Given this list of marker genes espC, HBB, hbp, tonB, dppA, dppD, mppA, dppC, exbB, exbD, dppB, chuA, HBA1, dppF, here is a description of the gene set: The ability to use iron derived from heme compounds represents an alternative iron uptake mechanism for enterobacteria growing in an iron-limited environment. Extracellular serine proteases of SPATE type (EspC, Hbp) cleave host hemoglobin, releasing free heme, which is imported by TonB-dependent receptors; binding of heme to a binding protein in the periplasm then enables cytosolic import by the ABC transporter DppBCDF. part of: Metal ion assimilation from the host Reactome Pathway: Heme assimilation studied in species Homo sapiens